The following is a description of a gene set: species: Homo sapiens from publication Nakaya HI, Wrammert J, Lee EK, Racioppi L, Marie-Kunze S, Haining WN, Means AR, Kasturi SP, Khan N, Li GM, McCausland M, Kanchan V, Kokko KE, Li S, Elbein R, Mehta AK, Aderem A, Subbarao K, Ahmed R, Pulendran B (PMID 21743478) Systems vaccinology has emerged as an interdisciplinary field that combines systems wide measurements and network and predictive modeling applied to vaccinology. Here we used the systems vaccinology approach to study the molecular mechanisms underlying th Genes up-regulated in comparison of monocytes from TIV influenza vaccinee pre-vaccination versus those at day 7 post-vaccination Human Gene Set: GSE29618_PRE_VS_DAY7_POST_TIV_FLU_VACCINE_MONOCYTE_UP, and this is the list of marker genes: MUC13, B3GALNT1, PPP3CA, PLEKHG3, BCORL1, ZC3H7A (NCBI Gene Id 54895), STK24, GSAP, ARAF, TTYH1, SERPINB10, RORA, TFAP2A, RNF128, GLUD1, BMP15, ZIC1, CCDC30, KCNE4, RETN, MFAP1, FAM153A, PCDH17, SEC31A, SNAP29, UBB, GPC4, GCK, ZBTB18, AJAP1, AICDA, CWF19L1, CELA3B, OGFR (opioid growth factor receptor), NDP, SLC27A6, ORC1 (origin recognition complex subunit 1), PTBP3, NLGN4X, TMEM43, PTH, ACTR1A, ZNF550 (zinc finger protein 550), NAA15, ATP1A3, TMEM204, BRS3, RNPS1, EMC9, SPATA6, KNL1, KCNA6, HAS1, ZNF334, FOXA2, HMX1, RBM48, PWAR5, DNASE1L1, TFPT, FUT4, QPRT, SSX3, ASPSCR1, ACKR2, BTG2-DT, ITGB1BP2, FHL5, WDR26, SLC22A7 (NCBI Gene Id 10864), WWOX, ERI3, ZNF37BP, VPREB3 (NCBI Gene Id 29802), KMT5A, RPS2P45, HPCA, ZNF157, TUBB (NCBI Gene Id 95295), STS, CS, ITPK1 (inositol-tetrakisphosphate 1-kinase), RPS11, GABRR1, SLC44A1, PRSS22, TAF13, CHRNB1, SNRPC, IL10RA, H4C4, IVNS1ABP, POPDC3, MAGOH2P, HOXB8, CRISP1, GON4L, EPB41, SAG, MYCL, SLC6A6, ZNF391, DCHS2, BRINP3, KRT85, PAIP2B, BNIP3, CLDN7, LY6E, PELO, VPS13B, TNFRSF9, DYNC2LI1, AFDN-DT, ACOT8, MMP1, CIC, DIXDC1, ZFX, DPYSL4, GSR, TAS2R8, RARS2, RSPH6A, RASSF8, CENPB, ROBO4 (roundabout guidance receptor 4), ZNF646, ZNF200, B3GALT4, WT1, ABCB8, ALOX15, LYRM9, AGBL5, FHOD3, SFRP4, MKRN3, NBEAL2, TECPR2, IL15, PPEF1, LAS1L, GNA13, IRF2BP1, MTAP (methylthioadenosine phosphorylase), RAB23, SPICE1, MMP13, PTGIS, NOCT, GNG3, HEATR6, BAAT, COX5B, CHRM3, G0S2, VPS37B, SNAPC1, MBTPS2, NEDD9, PDZD8, TOPORS, F12 (coagulation factor XII (Hageman factor)), CAMKK2, ITCH, NAMPT, ABCA1, GSN-AS1, PYY, LGI2 (NCBI Gene Id 55203), TRAK2, AKR1A1, SPTBN2, ZNF204P (NCBI Gene Id 7754), DUOX1, C2orf49, GNA14 (G protein subunit alpha 14), RBM34 (RNA binding motif protein 34), SRSF5, CNN1, TSPAN12, DTWD1, BIN3, CD48, TNP1, KIAA0753, FAM163A, RAB27B, HBEGF, CENPC, UNC5B, C7, TFRC, ADAMTS5, TREM2, TRAF3, KCTD2